The following is a description of a gene set: Generalized myoclonic-atonic seizure studied in species Homo sapiens A generalized myoclonic-atonic seizure is a type of generalized motor seizure characterized by a myoclonic jerk followed by an atonic motor component. Human Gene Set: HP_GENERALIZED_MYOCLONIC_ATONIC_SEIZURE, and this is the list of marker genes: SLC6A1, MED13, CHD2, SYNGAP1, SCN1A (NCBI Gene Id 6323), NEXMIF, CAMTA1, AP2M1, SLC32A1, SLC2A1, GLUL